The following is a description of a gene set: Primary active transporter that auto-phosphorylates (hence P) at a key conserved aspartate residue, generating a conformational change that allows transport of the substrate. Hydrolysis of the phosphorylated Asp residue, catalyzed by the actuator (A) domain, results in another state with occluded substrates. Upon dissociation of Mg2+ and Pi, the enzyme reverts to the initial state, in which the counter-transported substrate is released into the cytosol. Human Gene Set: GOMF_P_TYPE_TRANSMEMBRANE_TRANSPORTER_ACTIVITY species: Homo sapiens, and this is the list of marker genes: ATP13A4, ATP1A3, ATP2C1, ATP2C2, ATP2A1, ATP13A5, ATP1A2, ATP2B2, ATP1B1, ATP1A4, ATP2A2, TMEM94, ATP2A3, ATP13A1, ATP2B3, ATP7B, ATP4A, ATP12A, ATP13A2, ATP13A3, ATP1A1, ATP4B, ATP7A, ATP2B4, ATP2B1